The following is a description of a gene set: studied in species Homo sapiens The chemical reactions and pathways involving phylloquinone, a quinone-derived compound synthesized by green plants. Phylloquinone has vitamin K activity and is known as vitamin K1. Human Gene Set: GOBP_PHYLLOQUINONE_METABOLIC_PROCESS, and this is the list of marker genes: CYP4F2, CBR3, CYP4F3, CYP4F12, UBIAD1, CYP4F11, CYP4F8